Given this list of marker genes Psmc4, Phf20, Psmd12, Zfp385a, Psma7, Psma4, Rps27a, Psma2, Psmc6, Chek2, Ccna1, Ubb, Psmd1, Cdkn1a, Psma5, Trp53, Psmd6, Psmc5, Psmb5, Psmd13, Ccne2, Psma3, Psmb4, Psma6, Psmb6, Cdkn1b, Psmc1, Psmc2, Psmb7, Psmc3 (proteasome (prosome, macropain) 26S subunit, ATPase 3), Psmd7, Psma1, Ccne1, here is a description of the gene set: Reactome Pathway: p53-Dependent G1/S DNA damage checkpoint electronically inferred by orthology from the curated human pathway This event has been computationally inferred from an event that has been demonstrated in another species.<p>The inference is based on the homology mapping from PANTHER. Briefly, reactions for which all involved PhysicalEntities (in input, output and catalyst) have a mapped orthologue/paralogue (for complexes at least 75% of components must have a mapping) are inferred to the other species. species: Mus musculus part of: G1/S DNA Damage Checkpoints